The following is a description of a gene set: Genes involved in p53 pathways and networks. Human Gene Set: HALLMARK_P53_PATHWAY studied in species Homo sapiens from publication Liberzon A, Birger C, Thorvaldsdóttir H, Ghandi M, Mesirov JP, Tamayo P (PMID 26771021), and this is the list of marker genes: GADD45A, BTG1, ZNF365, KLK8, GLS2, SLC19A2, INHBB, MXD4, PVT1, PHLDA3, PLXNB2, TGFA, PIDD1, STOM, IRAK1, TCHH, CTSF, SP1, TM7SF3, ANKRA2, PLK3, ADA, IP6K2, RXRA, BLCAP, PRMT2, DCXR, IER5, NOL8, H1-2, TRIB3, TPD52L1, PDGFA, TRAF4, EPHX1, NHLH2, CD82 (CD82 molecule), RETSAT, HBEGF, PMM1, CCNK, ALOX15B, TM4SF1, MXD1, CTSD, SLC3A2, SERTAD3, TSC22D1, CDKN2B, UPP1, H2AC25, APP, FOS, ABCC5, RAD9A, POLH, IER3, VWA5A, VAMP8, TNFSF9, TAX1BP3, ACVR1B, STEAP3, FOXO3, HEXIM1, OSGIN1, BMP2, SERPINB5 (serpin family B member 5), FAM162A, HSPA4L, CCP110, CYFIP2, TCN2, VDR, SESN1, CSRNP2, SLC35D1, GPX2 (NCBI Gene Id 2877), PITPNC1, EI24, DDIT4, FAS, FGF13, CCND2, ABHD4, HDAC3, APAF1, TSPYL2 (NCBI Gene Id 64061), RGS16, CDH13, NUDT15, TGFB1, CGRRF1, SDC1, JUN (Jun proto-oncogene, AP-1 transcription factor subunit), COQ8A (NCBI Gene Id 56997), HMOX1, RNF19B, PPP1R15A, SAT1, AK1, IRAG2, GM2A, CD81, TRIAP1, ZBTB16, BTG2, RCHY1, TAP1, PCNA, MDM2, FDXR, AEN, DDB2, ABAT (4-aminobutyrate aminotransferase), KIF13B (NCBI Gene Id 23303), RB1, RACK1, RPL36, PERP, CEBPA, RRAD, NINJ1, KLF4, EPHA2, RAB40C, BAX, RRP8, TOB1, ELP1, PRKAB1, RALGDS, ISCU, DEF6, EPS8L2, RAD51C, ZFP36L1, KRT17, CDK5R1, NDRG1, ZMAT3, PROCR, NUPR1 (NCBI Gene Id 26471), SPHK1, RHBDF2, HRAS, PPM1D, CLCA2, PTPRE, IFI30, JAG2, TRAFD1, CCND3, SOCS1, CCNG1, XPC, POM121, SLC7A11, FBXW7, RAP2B, RPS12 (NCBI Gene Id 6206), LIF (NCBI Gene Id 3976), CASP1, BAIAP2, PTPN14, ATF3, IL1A (NCBI Gene Id 3552), TNNI1, DDIT3, S100A4, H2AJ, SEC61A1, ERCC5, TXNIP, WWP1, S100A10, DRAM1, CDKN2A, MKNK2 (NCBI Gene Id 2872), SFN, TPRKB, PLK2, ITGB4, TP53, DNTTIP2, MAPKAPK3, NOTCH1, TP63, FUCA1, DGKA, RPL18, F2R, LDHB, ST14, CDKN1A, RPS27L, BAK1, WRAP73, HINT1, CDKN2AIP